The following is a description of a gene set: Thyroid dysgenesis is a descriptive term that should be avoided if more precise information is available. However, the HPO keeps retains this term because it is commonly used in the medical literature. In humans, the process of thyroid morphogenesis occurs from the 3rd to 16th week of gestation. Alterations occurring during this period may result in a thyroid gland that is absent (thyroid agenesis or athyreosis), hypoplastic (thyroid hypoplasia), or located in an unusual position (thyroid ectopy). All these entities are grouped under the term thyroid dysgenesis. studied in species Homo sapiens Thyroid dysgenesis Human Gene Set: HP_THYROID_DYSGENESIS, and this is the list of marker genes: GLI3, PAX8, LIFR, KAT6B, NKX2-1, NKX2-5